Given this list of marker genes FAS, XIAP, FASLG, MYC, NFATC2, RHOH, SH2D1A, CASP10, here is a description of the gene set: Human Gene Set: HP_BURKITT_LYMPHOMA species: Homo sapiens A form of undifferentiated malignant lymphoma commonly manifested as a large osteolytic lesion in the jaw or as an abdominal mass. Burkitt lymphoma